Given this list of marker genes SLC25A5, ITGB1BP1, RPLP0, SDHB, CCT7, FAU, SOD1, ARF1 (ADP ribosylation factor 1), MED10, KIF9, CYC1, TIMM44, MT-CO3, CAPRIN1, GALE, ATP6V1D, CRYL1, KIT, CHTOP, PEPD, TPCN2, CRTAP, ENOPH1, TUFM, NDUFA4, RBM23, TAX1BP3, ATG101, NDUFAF4, ERP29, JAGN1, UBE2D1, KCNJ13, ALX1, DHPS, GADD45GIP1, USP32, GRSF1, MT-CO1, SNRPG, OCA2, SNRPE, TAF9, ETF1, ST6GALNAC2, TSG101, CHCHD3, XAB2, DLC1 (NCBI Gene Id 94517), DNAJA4, EIF3G, ALDOA, STAM, SEMA3E, UBE2E1, PRELID1, EIF3H, TPMT, MT-CYB, PFDN6, TCEAL9, KARS1, RSL1D1, HIBADH, MT-ND3, COX6A1, FBXO7, AP2M1, SLC35B2, MORF4L1 (mortality factor 4 like 1), TSN, ZPR1, NUDC, SYPL1, ATP5F1D, NGDN, CAMTA1, R3HCC1L, SRI, BIN3, SNX2, EIF3M, SLC6A17 (solute carrier family 6 member 17), BEX2, SLC4A2, B3GAT3, CCT5, CYB5R1, RPF2, MT-ND1, LSM7, UNK, PDLIM3, AHSA1, RETREG2, PPAN, EHBP1, IMP4, LYSET, PSMC3, NET1 (neuroepithelial cell transforming 1), NOP56, MT-ND2, NOL12, CCNG1 (NCBI Gene Id 900), SLIRP, EIF2S2, GABARAP, DPH3 (NCBI Gene Id 285381), NELFCD, USF2, ERBB3, MRFAP1, KLHL21, TOMM22, SGK1, SUMO3, CHCHD2, XPC, RTTN, RNH1, CUTA, CYCS, ZNF704, SNHG8 (NCBI Gene Id 100093630), KLF6, ROPN1B, MRPL57, ESF1, IRF4 (interferon regulatory factor 4), NELFE, GTF3C6, MRPS18C, ATP5PO, ATP5MG, MT-CO2, RSRC2, ATP5PF, DAD1, RAD23A, SECISBP2, SNX8, PHF1, ATP5MK, BCAN, AKAP8, ODF2L (NCBI Gene Id 57489), DEK, SAP18, TAF7, PHB1, RNF145, DAAM1, COX7C, VDAC2, UQCRFS1, here is a description of the gene set: species: Homo sapiens from publication Gautam P, Hamashima K, Chen Y, Zeng Y, Makovoz B, Parikh BH, Lee HY, Lau KA, Su X, Wong RCB, Chan WK, Li H, Blenkinsop TA, Loh YH (PMID 34584087) Occular cell types curated from Gautam and Hamashima et al. Multi-species single-cell transcriptomic analysis of ocular compartment regulons Human Gene Set: GAUTAM_EYE_CHOROID_SCLERA_MELANOCYTES